Given this list of marker genes MATR3, RAVER2, DYRK1A, IL17RB (interleukin 17 receptor B), ARID1A, APBB1IP, RANBP10, GRK6, TRAF6, PRDM1 (NCBI Gene Id 639), TMX4, MIR30E, SPI1, RNF125, KCNRG, TBC1D15, SRGN, AHNAK, RARG, DNTT, MYL10 (myosin light chain 10), TGFBR3, LRP1, NMB, KLF13 (KLF transcription factor 13), WDR45B, TXNIP, TAF8, TNKS2, ATP2A3, GGPS1, MYL12B, RNF139, FEZ2, ABHD2, SARAF, ADAMDEC1, CCDC117, KBTBD2, B4GALT1, TYROBP, ADAM19, SLC16A5, ZFAND6, NIPAL3, PPP1R13B, ZNF394, NCK2, GBA2, ZNRF3, GGT1, ACOX1, EXT1, ZYG11B, EIF2AK3 (NCBI Gene Id 9451), TANC1, CD300LD, CLEC9A, PRKAB1, SMG6, IGSF6, PSTPIP1, TSPO, ARHGAP9, TREML2, GCH1, PGAP6, ENTPD1, TOB1, KBTBD7, MAFK, DCAF5, NCR1, ANXA6, SNX4, C1orf54, RORA, PNPLA8, PIK3R5, UBC, KLF7, CRTC3, SAMD8, ID2, EML3, WDR7, TLR8, PAIP2B, GZMA, SYTL1, SLC22A5, IQGAP1, IRF7, SH3PXD2A, ZFP36L2, IER5, CLEC1B, RNF103, ZNFX1, VPS37B, RETREG3, ZSWIM6, CCL5, PRAMEF8, GOLM1, HDAC5, TMEM123, CD163L1, TMEM176B, RNF13, TRIM13, TTC7A (NCBI Gene Id 57217), PLEKHM1, DUSP5, SOX4, XYLT1 (NCBI Gene Id 64131), MIA3, COQ10B, AKNA, CELF2, MXD1, TRIM26, RCN3, RC3H1, MICAL1, USF2, TLE5 (NCBI Gene Id 166), NFATC2, MYO9B, CCR7 (C-C motif chemokine receptor 7), XPR1, IRF2BP2, GATA3, USP12, SNORD73B, DGKD, CEP295NL, POLG2, CIRBP, ADGRE4P, SUGCT, MTMR3, TAX1BP1, FLNA, GABARAPL2, FURIN, DMXL1, GALNT6, CBX4, TNFRSF25, PPM1H, PPP3CA, BIRC3, DCTN6, LPCAT2, CYP39A1, EXOC6B, LYN, S1PR5, AMPD3, SYS1, RNF138, THEMIS2, PLBD1, FRMD4B, STAU1, AHR, WDFY4, PIK3CD, ARHGEF4, ADGRG3, FNBP1, FOXK1, LATS2, MYO18A, here is a description of the gene set: Human Gene Set: GSE15271_CXCR4_POS_VS_NEG_GC_BCELL_DN species: Homo sapiens Functional discrimination between normal centroblast and centrocyte obtained from human inflamed tonsils after cell sorting. We used microarrays to detail the segregation between these two B cell subsets from publication Caron G, Le Gallou S, Lamy T, Tarte K, Fest T (PMID 19494283) Genes down-regulated in centroblasts versus centrocytes.